Given this list of marker genes Mre11a, Rad50, Xrcc5, Prkdc, Xrcc4 (NCBI Gene Id 71945), Nhej1, Xrcc6, here is a description of the gene set: studied in species Mus musculus Mouse Gene Set: WP_NONHOMOLOGOUS_END_JOINING Non-homologous end joining